The following is a description of a gene set: studied in species Mus musculus from publication Tabula Muris Consortium (PMID 32669714) Mouse Gene Set: TABULA_MURIS_SENIS_LUNG_TYPE_II_PNEUMOCYTE_AGEING, and this is the list of marker genes: Naca (nascent polypeptide-associated complex alpha polypeptide), Map1lc3a, Clic1 (chloride intracellular channel 1), Klf2, Ybx1, Cfl1, Prr13, Tsc22d1, Cldn3 (claudin 3), H2-D1, Cryab, Rpl13a, Drap1, Hspb1, H2-K1, Rps13, Eif5a, Ccnd3, B2m, Fth1, Uba52, Tomm6, Gapdh, Arhgdib, Arhgdia, Use1, Hspe1, Tle5, Ly6a, Rpl28, Jund, Arpc1b, Pfn1, Rheb, Rpsa, Irx3, Fasn (fatty acid synthase), Nrn1